The following is a description of a gene set: Human Gene Set: GOBP_POSITIVE_REGULATION_OF_ENDOPLASMIC_RETICULUM_STRESS_INDUCED_INTRINSIC_APOPTOTIC_SIGNALING_PATHWAY Any process that activates or increases the frequency, rate or extent of an endoplasmic reticulum stress-induced intrinsic apoptotic signaling pathway. studied in species Homo sapiens, and this is the list of marker genes: BBC3, PMAIP1, NCK1, PTPN2, BCL2L11, RNF183, NCK2, DDIT3, SERINC3, SIRT1, BOK